Given this list of marker genes CD93, NRIP1, SATB1, FLT3, EDNRA, CALCRL, PTPRCAP, TSC22D1, ITGB7, CD27, TSPAN2, MEIS1, CD34, CD244, ERG, IL7R, TMSB10, NRGN, OAF, LY86, EBF1, CXXC5, GEM, ADGRG1, here is a description of the gene set: Down-regulated genes in myeloid progenitors immortalized by HOXA9 vs those immortalized by HOXA9 and MEIS1. Meis1 is a homeodomain transcription factor coexpressed with Hoxa9 in most human acute myeloid leukemias (AMLs). In mouse models of leukemia produced by Hoxa9, Meis1 accelerates leukemogenesis. Because Hoxa9 immortalizes myeloid progenitors in the absence of Meis1 expression, the contribution of Meis1 toward leukemia remains unclear. Here, we describe a cultured progenitor model in which Meis1 programs leukemogenicity. Progenitors immortalized by Hoxa9 in culture are myeloid-lineage restricted and only infrequently caused leukemia after more than 250 days. Coexpressed Meis1 programmed rapid AML-initiating character, maintained multipotent progenitor potential, and induced expression of genes associated with short-term hematopoietic stem cells (HSCs), such as FLT3 and CD34, whose expression also characterizes the leukemia-initiating stem cells of human AML. Meis1 leukemogenesis functions required binding to Pbx, binding to DNA, and a conserved function of its C-terminal tail. We hypothesize that Meis1 is required for the homing and survival of leukemic progenitors within their hematopoietic niches, functions mediated by HSC-specific genes such as CD34 and Fms-like tyrosine kinase 3 (FLT3), respectively. This is the first example of a transcription factor oncoprotein (Meis1) that establishes expression of a tyrosine kinase oncoprotein (FLT3), and explains their coexpression in human leukemia. This cultured progenitor model will be useful to define the genetic basis of leukemogenesis involving Hoxa9 and Meis1. from publication Wang GG, Pasillas MP, Kamps MP (PMID 15755900) Human Gene Set: WANG_IMMORTALIZED_BY_HOXA9_AND_MEIS1_DN species: Mus musculus